The following is a description of a gene set: studied in species Homo sapiens Human Gene Set: DESCARTES_FETAL_PANCREAS_VASCULAR_ENDOTHELIAL_CELLS from publication Cao J, O'Day DR, Pliner HA, Kingsley PD, Deng M, Daza RM, Zager MA, Aldinger KA, Blecher-Gonen R, Zhang F, Spielmann M, Palis J, Doherty D, Steemers FJ, Glass IA, Trapnell C, Shendure J (PMID 33184181) Marker genes curated from the annotated cluster as represented in the Descartes Human Gene Expression During Development database. The gene expression program underlying the specification of human cell types is of fundamental interest. The study authors generated human cell atlases of gene expression and chromatin accessibility in fetal tissues. For gene expression, the study authors applied three-level combinatorial indexing to >110 samples representing 15 organs, ultimately profiling ~4 million single cells. The study authors leveraged the literature and other atlases to identify and annotate hundreds of cell types and subtypes, both within and across tissues. Our analyses focused on organ-specific specializations of broadly distributed cell types (such as blood, endothelial, and epithelial), sites of fetal erythropoiesis (which notably included the adrenal gland), and integration with mouse developmental atlases (such as conserved specification of blood cells). These data represent a rich resource for the exploration of in vivo human gene expression in diverse tissues and cell types., and this is the list of marker genes: ESM1, TM4SF18, ACSM2B, JAG2, TMEM88, ENSG00000253348, EXOC3L1, FOXI2, PLVAP, SEMA6B, SSUH2, VSIG2, SLC9C1, MADCAM1-AS1, F2RL3, CLEC14A, NOTCH4, HAPLN1, AQP7, PRND, FAM124B, RP1L1, LINC01936, LHX6, ADM5, FCN3, TCIM, MALL, OIT3, ESAM, IFI27, C1QTNF9, COL15A1, PCDH12, UPB1, ADAD2, SCN4A (NCBI Gene Id 6329), ALPL, BCL6B, CYYR1, COL13A1, CRYBB3, AVPR2, HSPG2, JAM2, MIR126, APLN, NOSTRIN, SOX7, CLEC3B, CD93, TCF15, SPAAR, FAM167B, ARHGEF15 (NCBI Gene Id 80081), CD109, CIMAP1D, CD34, BHLHE40-AS1, BTNL9, ENSG00000233251 (NCBI Gene Id 100129434), TM4SF18-AS1, FLT1, SOX17, MMRN2, CD320